Given this list of marker genes G3bp1, Lsm4, Arhgdia, Ifih1, Arid5b, Ndufab1, Trim30a, Calm1 (calmodulin 1), Tpm3, Herc6, Psmb3, Timm10, Macroh2a1, Fabp5, Hsp90aa1, Trib2, Mybbp1a, Bcl3, Crem, Casp8, Pml, Cct3 (chaperonin containing TCP1 subunit 3), Psmd12, Mrpl23, Psme2, Castor1, Rnf213, Adar, Rigi, Hspa5, Socs2, Ccnd2, Mat2a, Tap1, Vim, Psmb9, Ifi47, Itih5, Cmtm6, Hspa8, Parp10, Igtp, Nlrc5, Serbp1, Ddx21, Timm8a1, Snu13, Ifi214, Nmi, Slfn1, Cltb, Foxp3, Hspa9, Fam162a, Eno1, Pfdn6, Aida, Sbno2, Eif4a1, Cct8, Gbp7, Mbd2, Stat1, Daxx, H2-T23, Rars1, Pa2g4 (proliferation-associated 2G4), Hopx, Lsm7, Ddx39a, Slc25a5, Psme1, Ifit3, Treml2, Atp5mc1, Irf1, Mndal, Serpina3g, Psmb5, Dkc1, H2-T22, Mthfd2, Eif2ak2, Gbp5 (guanylate binding protein 5), Gbp6, St6galnac4, Ifit1bl1, Gpr18 (NCBI Gene Id 263515), Wdr43, Mrpl15, Capn2, Timm9, Ifi35, Gbp2, Zbp1, Mif, Cyc1, Bcl2, Nt5c, Nampt, Trim12c, Pcbp1 (NCBI Gene Id 23983), Impdh2, Ifngr1, Tap2, Oat, Mrpl21, Lrrc32, Bst2, Cd47, Ddx60, Iigp1 (interferon inducible GTPase 1), C1qbp, Psmb10 (proteasome (prosome, macropain) subunit, beta type 10), Ncoa7, Tuba4a, Il2rb, Tmed10, Ndufa12, Ifi208, Cox7b, Ranbp1 (RAN binding protein 1), Phf11c, Ncl, Dhx58, Atp5f1d, Ppp1r14b, Hsp90ab1, Hspa4, Aimp2 (aminoacyl tRNA synthetase complex-interacting multifunctional protein 2), Samd9l, Samhd1, Ptpn1, Epcam, Socs1, Tapbpl, Ewsr1, Gpr83, Nop56, Cox5a, Slfn5, Oasl2, Abi3, Psmd6, Usp18, Isy1, Mrpl30, Isg15, Tuba1b, Nsun2, Ogfr, Eif1ax, Atp5f1b, Psma7, Pmepa1, Helz2, Stat2, Vars1, Irf7, Ifi203, Slfn8, Trim30d, Xaf1, Capg, Eif4a3, Nudc, Phf11b, Nhp2, Snrpa1, Mrps28, Prmt1, Stat3, Chmp4b, Actg1, Epsti1, Rexo2, Rtp4, Ran, Cct7, Isg20, Uqcc2, Fkbp4, Cndp2, Banf1, Irgm1, Ldha, Gbp4 (guanylate binding protein 4), Tubb4b, Npm3, Phgdh, Psma5, Cycs, Ifi206, Larp1, Cd2, Calr, Rbx1, Gadd45g, Ptma, Eprs1, Atp9b, Ifi27l2a, Tex2, Npm1, Cct5, C1qtnf12, Mov10, Ifi209, Tcof1, Magoh, Tomm40, Park7, Bzw2, Osm, Tnfrsf4, Ifit1, Lta, Sp100, Uchl3, Gbp3, Apex1, Nabp1, Ppa1, Cd274, Parp9, Polr2f, Eif5a, Eeig1, Slfn2, Mthfd1, Wars1, Timm50, Ly6a, Socs3, Nme1, Mitd1, Cish, Srsf3, Cytip, Fbl, Parp14, Dtx3l, Tapbp, Lgals3bp, Calhm6, Irf9, Tmed5, Psmb8, Tnfrsf18, here is a description of the gene set: from publication Cui A, Huang T, Li S, Ma A, Pérez JL, Sander C, Keskin DB, Wu CJ, Fraenkel E, Hacohen N (PMID 38057668) Mouse Gene Set: CUI_TREG_IL15_RESPONSE_UP Genes positively differentially expressed in cell type: Treg upon treatment with cytokine: IL-15 in mouse lymph nodes in vivo. species: Mus musculus Cytokines mediate cell-cell communication in the immune system and represent important therapeutic targets. A myriad of studies have highlighted their central role in immune function, yet we lack a global view of the cellular responses of each immune cell type to each cytokine. To address this gap, the authors created the Immune Dictionary, a compendium of single-cell transcriptomic profiles of more than 17 immune cell types in response to each of 86 cytokines (>1,400 cytokine-cell type combinations) in mouse lymph nodes in vivo. A cytokine-centric view of the dictionary revealed that most cytokines induce highly cell-type-specific responses. For example, the inflammatory cytokine interleukin-1β induces distinct gene programmes in almost every cell type. A cell-type-centric view of the dictionary identified more than 66 cytokine-driven cellular polarization states across immune cell types, including previously uncharacterized states such as an interleukin-18-induced polyfunctional natural killer cell state.